The following is a description of a gene set: The cleavage furrow is a plasma membrane invagination at the cell division site. The cleavage furrow begins as a shallow groove and eventually deepens to divide the cytoplasm. Human Gene Set: GOCC_CLEAVAGE_FURROW species: Homo sapiens, and this is the list of marker genes: OR2A4, MEN1, RAB11FIP4, PSD, PITPNM1, PKN2, RHOB, RAB11FIP3, PLK4, PSTPIP1, RALA, STAMBP, NDE1, SPIRE1, MASTL, SSH1, PPP1CC, SPIRE2, ITGB1, KIF20A, MYH9, RACGAP1, ECT2, ANKRD45, PKN1, KATNBL1, NF2, ZFYVE19, WDR73, PSD4, PDXP, PSD2, DCTN3, HTR3A, SEPTIN7, CEP55, RHOC, SVIL, MYLK, SEPTIN12, HMCN1, PLEKHG6, RHOA, LIMA1, ARF6, DIAPH3, SEPTIN2, MYH10, RAB11A, SEPTIN6, RAB21, ICAM2, RDX, PLCD3, FSD1, HMCN2